Given this list of marker genes SGCG, MAPK3, TRIP12, LILRB3, SYP, CBL, KRT34, USP13 (NCBI Gene Id 8975), VAV2, IL2RA, KIZ, MLPH, DCLK1, CCL28, TSPAN5, GFPT2 (glutamine-fructose-6-phosphate transaminase 2), ODAM, PTGES, LINC02366, CD274, IRAK1, MFAP3L, FBXW8, SPI1, ABCA8, MATN1 (NCBI Gene Id 4146), MATN2, IGSF10, FRZB, PCSK6, CCL11, KCNQ2, RAD51B (NCBI Gene Id 5890), TMA16, CD34, C16orf86, CD38, KLHL9, F5, LHB, SHISA9, FCGBP, CABIN1, ME3, LMLN, ROGDI, JUP, BAP1, FLT4, KLK2, PLCG2, PPIL4, CT75, CDH16, PRUNE1, RANBP10, MT1A, GPD1, ZNF275, CYTH3, RUNX3 (RUNX family transcription factor 3), BMP5, CD33, PTPN4, KLRD1, E2F5, RNF32, ASGR1, ZNF44, STYXL1, SPEF2 (NCBI Gene Id 80192), IL24, BAK1, SPATA3-AS1, SH3RF2, HOXD11, TWIST1, DIO1, PICK1, KLF1, here is a description of the gene set: Genes down-regulated in papillary thyroid carcinoma (PTC) compared to other thyroid tumors. Conventional histology failed to classify part of non-medullary thyroid lesions as either benign or malignant. The group of tumours of uncertain malignancy (T-UM) concerns either atypical follicular adenomas or the recently called 'tumours of uncertain malignant potential'. To refine this classification we analysed microarray data from 93 follicular thyroid tumours: 10 T-UM, 3 follicular carcinomas, 13 papillary thyroid carcinomas and 67 follicular adenomas, compared to 73 control thyroid tissue samples. The diagnosis potential of 16 selected genes was validated by real-time quantitative RT-PCR on 6 additional T-UM. The gene expression profiles in several groups were examined with reference to the mutational status of the RET/PTC, BRAF and RAS genes. A pathological score (histological and immunohistochemical) was estimate for each of the T-UM involved in the study. The correlation between the T-UM gene profiles and the pathological score allowed a separation of the samples in two groups of benign or malignant tumours. Our analysis confirms the heterogeneity of T-UM and highlighted the molecular similarities between some cases and true carcinomas. We demonstrated the ability of few marker genes to serve as diagnosis tools and the need of a T-UM pathological scoring. from publication Fontaine JF, Mirebeau-Prunier D, Franc B, Triau S, Rodien P, Houlgatte R, Malthièry Y, Savagner F (PMID 17968324) studied in species Homo sapiens Human Gene Set: FONTAINE_PAPILLARY_THYROID_CARCINOMA_DN